The following is a description of a gene set: Reactome Pathway: TRIF (TICAM1)-mediated TLR4 signaling This event has been computationally inferred from an event that has been demonstrated in another species.<p>The inference is based on the homology mapping from PANTHER. Briefly, reactions for which all involved PhysicalEntities (in input, output and catalyst) have a mapped orthologue/paralogue (for complexes at least 75% of components must have a mapping) are inferred to the other species. species: Mus musculus electronically inferred by orthology from the curated human pathway part of: MyD88-independent TLR4 cascade , and this is the list of marker genes: Map2k3, Nlrx1, Nkiras1, Nfkb1, Map2k4, Map2k7, Tab3, Casp8, Tlr4, Mapk14, Dusp7, Ppp2r1b, Irf3, Cul1, Ppp2r5d, Ube2n (NCBI Gene Id 93765), Traf3, Ager, Optn, Irak1, Ube2d1, Ikbkb, Cd14, Mapk7, Mapk8, Mapk11, Tab2, Fadd, Map2k6, Rps27a, Tab1, Jun, Fos, Map3k8, Lrrc14, Mapk9, Rela, Irf7, Nfkbia (NCBI Gene Id 18035), Nlrc5, Nfkb2, Ube2v1, Ticam2, Tifa, Mapk3, Vrk3, Rps6ka5, Birc3 (baculoviral IAP repeat-containing 3), Nfkbib, Dusp6, Ubb, Ly96, Hmgb1, S100b